Given this list of marker genes TIMP1, PPP1R9B, NPR2, KLF15, KLF2, SMPD3, KLF5, KLF4, KLF3, ANO1, KLF11, IRS2, KLF1, FIS1, CASR, AKT1, here is a description of the gene set: species: Homo sapiens Human Gene Set: GOBP_CELLULAR_RESPONSE_TO_PEPTIDE Any process that results in a change in state or activity of a cell (in terms of movement, secretion, enzyme production, gene expression, etc.) as a result of a peptide stimulus.